Given this list of marker genes NLRC5, ARG1, JAK2, PTPN2, IRGM, NR1H2, PARP9, IFNGR2 (NCBI Gene Id 3460), HCK, HPX, CDC37, PPARG, STAT1, OTOP1, JAK1, IFNGR1, DNAJA3, CIITA, TP53, PARP14, TXK, SP100, NR1H3, TYK2, MED1, IRF1, RAF1, IFNG, here is a description of the gene set: Human Gene Set: GOBP_TYPE_II_INTERFERON_MEDIATED_SIGNALING_PATHWAY species: Homo sapiens The series of molecular signals initiated by interferon-gamma binding to its receptor on the surface of a target cell, and ending with the regulation of a downstream cellular process, e.g. transcription. Interferon gamma is the only member of the type II interferon found so far.